Given this list of marker genes MYL6, MYH11, MYLK, PPP1R12A, MYH9, RAC1 (Rac family small GTPase 1), PAK2, PAK3, MYH10, PPP1R12B, FLNA, PAK1, MYL12B, CDC42, NF2, MYH14, PPP1CB, CALM1 (NCBI Gene Id 801), MYL9, CTTN, LIMK1, here is a description of the gene set: The PAKs (p21-activated kinases) are a family of serine/threonine kinases mainly implicated in cytoskeletal rearrangements. All PAKs share a conserved catalytic domain located at the carboxyl terminus and a highly conserved motif in the amino terminus known as p21-binding domain (PBD) or Cdc42/Rac interactive binding (CRIB) domain. There are six mammalian PAKs that can be divided into two classes: class I (or conventional) PAKs (PAK1-3) and class II PAKs (PAK4-6). Conventional PAKs are important regulators of cytoskeletal dynamics and cell motility and are additionally implicated in transcription through MAPK (mitogen-activated protein kinase) cascades, death and survival signaling and cell cycle progression.<p>PAK1, PAK2 and PAK3 are direct effectors of RAC1 and CDC42 GTPases. RAC1 and CDC42 bind to the CRIB domain. This binding induces a conformational change that disrupts inactive PAK homodimers and relieves autoinhibition of the catalytic carboxyl terminal domain. Autophosphorylation of a conserved threonine residue in the catalytic domain of PAKs (T423 in PAK1, T402 in PAK2 and T436 in PAK3) is necessary for the kinase activity of PAK1, PAK2 and PAK3. Autophosphorylation of PAK1 serine residue S144, PAK2 serine residue S141, and PAK3 serine residue S154 disrupts association of PAKs with RAC1 or CDC42 and enhances kinase activity. LIMK1 is one of the downstream targets of PAK1 and is activated through PAK1-mediated phosphorylation of the threonine residue T508 within its activation loop. Further targets are the myosin regulatory light chain (MRLC), myosin light chain kinase (MLCK), filamin, cortactin, p41Arc (a subunit of the Arp2/3 complex), caldesmon, paxillin and RhoGDI, to mention a few.<p>Class II PAKs also have a CRIB domain, but lack a defined autoinhibitory domain and proline-rich regions. They do not require GTPases for their kinase activity, but their interaction with RAC or CDC42 affects their subcellular localization. Only conventional PAKs will be annotated here. Reactome Pathway: RHO GTPases activate PAKs part of: RHO GTPase Effectors studied in species Homo sapiens